Given this list of marker genes SPAM1, ARSB, HYAL1, HYAL3 (NCBI Gene Id 8372), HYAL4, HYAL2, IDS, IDUA, here is a description of the gene set: Dermatan sulfate degradation. Pathway ID: N00610. Pathway type: Reference. Pathway class: nt06012 Glycosaminoglycan degradation. Pathway Definition from KEGG: DS -- IDS >> IDUA >> ARSB >> HYAL -> G00872 species: Homo sapiens Human Gene Set: KEGG_MEDICUS_REFERENCE_DERMATAN_SULFATE_DEGRADATION